The following is a description of a gene set: part of: Chromatin modifying enzymes studied in species Mus musculus Reactome Pathway: HATs acetylate histones electronically inferred by orthology from the curated human pathway This event has been computationally inferred from an event that has been demonstrated in another species.<p>The inference is based on the homology mapping from PANTHER. Briefly, reactions for which all involved PhysicalEntities (in input, output and catalyst) have a mapped orthologue/paralogue (for complexes at least 75% of components must have a mapping) are inferred to the other species., and this is the list of marker genes: H2bc7, Kat7, H2bc9, Ing4, H2bc13, H2bc27, H2bc8 (H2B clustered histone 8), H4c4, H3c8, Brpf1, H4c18, Ncoa1, H3c1, H3c4, Rbbp7, H4c11, H2bc14, H3c15, Pax3, Msl3 (MSL complex subunit 3), H4c2, H3c10 (NCBI Gene Id 319152, H3 clustered histone 10), H4c6, Brpf3, H2bc3, H4c8, H4c9 (NCBI Gene Id 319158), H2bc12, H4c17, Kansl2, Jade2, Jade3, H3c3, H3c7, Kansl1, Msl2, H4c12, H2bc1 (NCBI Gene Id 319177), H2bc11, H4c1, H3c11, Hcfc1, Phf20, H3c6, Kat6b, H4c14, H3c2, H3c13 (NCBI Gene Id 319154), H4c3, H2bc22, H2bc15